Given this list of marker genes TJP1, CDH1, TWIST1, CDH4, CDH3, SNAI3, TRIM28, SNAI1, HNRNPAB, here is a description of the gene set: species: Mus musculus Dysregulation of protein kinase A (PKA) activity, caused by loss of function mutations in PRKAR1A, is known to induce tumor formation in the inherited tumor syndrome Carney complex (CNC) and is also associated with sporadic tumors of the thyroid and adrenal. We have previously shown that Prkar1a(+/-) mice develop schwannomas reminiscent of those seen in CNC and that similar tumors are observed in tissue-specific knockouts (KO) of Prkar1a targeted to the neural crest. Within these tumors, we have previously described the presence of epithelial islands, although the nature of these structures was unclear. In this article, we report that these epithelial structures are derived from KO cells originating in the neural crest. Analysis of the mesenchymal marker vimentin revealed that this protein was markedly down-regulated not only from the epithelial islands, but also from the tumor as a whole, consistent with mesenchymal-to-epithelial transition (MET). In vitro, Prkar1a null primary mouse embryonic fibroblasts, which display constitutive PKA signaling, also showed evidence for MET, with a loss of vimentin and up-regulation of the epithelial marker E-cadherin. Reduction of vimentin protein occurred at the posttranslational level and was rescued by proteasomal inhibition. Finally, this down-regulation of vimentin was recapitulated in the adrenal nodules of CNC patients, confirming an unexpected and previously unrecognized role for PKA in MET. Epithelial and mesenchymal markers up-regulated in MEF cells (embryonic fibroblasts) after knockout of PRKAR1A. Human Gene Set: NADELLA_PRKAR1A_TARGETS_UP from publication Nadella KS, Jones GN, Trimboli A, Stratakis CA, Leone G, Kirschner LS (PMID 18413734)